Given this list of marker genes PLXNA3, NRP1, EGR2, HOXB1, KCNA2, HOXB2, NRP2, PAX2, SEMA3A, SEMA3F, PLXNA4, here is a description of the gene set: Human Gene Set: GOBP_CRANIAL_NERVE_STRUCTURAL_ORGANIZATION studied in species Homo sapiens The process that contributes to the act of creating the structural organization of the cranial nerves. This process pertains to the physical shaping of a rudimentary structure. The cranial nerves are composed of twelve pairs of nerves that emanate from the nervous tissue of the hindbrain. These nerves are sensory, motor, or mixed in nature, and provide the motor and general sensory innervation of the head, neck and viscera. They mediate vision, hearing, olfaction and taste and carry the parasympathetic innervation of the autonomic ganglia that control visceral functions.